The following is a description of a gene set: Human Gene Set: HP_ABNORMAL_NAIL_ATTACHMENT species: Homo sapiens An anomaly of the connection of the nail to the nailbed. Abnormal nail attachment, and this is the list of marker genes: NOP10 (NCBI Gene Id 55505), IFIH1, ITGA3, DKC1, NHP2, DSG1, ITGB4 (NCBI Gene Id 3691), CDSN, PPP1R13L, HOXC13, KRT14, LAMA3, KRT74, UROD, COL7A1, HLA-C, JUP (junction plakoglobin), KRT85, KRT5, WNT10A, GJB6, CAST, FZD6, ATR